Given this list of marker genes BLK, RUNX1, ELF2, ELF1, CBFB, PAX5, here is a description of the gene set: Reactome Pathway: RUNX1 regulates transcription of genes involved in BCR signaling species: Homo sapiens part of: Transcriptional regulation by RUNX1 The RUNX1:CBFB complex, in association with transcription co-factors ELF1 (MEF), ELF2 (NERF2) or PAX5 (BSAP) stimulates transcription of the BLK gene, encoding a B-cell specific tyrosine kinase involved in B cell receptor (BCR) signaling, B cell development and differentiation.